The following is a description of a gene set: Genes up-regulated macrophages with MYD88 knockout: untreated versus 12h after M. bovis BCG infection. from publication Qualls JE, Neale G, Smith AM, Koo MS, DeFreitas AA, Zhang H, Kaplan G, Watowich SS, Murray PJ (PMID 20716764) Human Gene Set: GSE22935_UNSTIM_VS_12H_MBOVIS_BCG_STIM_MYD88_KO_MACROPHAGE_UP Nitric oxide (NO) produced by macrophages (MØs) is toxic to both host tissues and invading pathogens and its regulation is therefore essential to suppress host cytotoxicity. MØ arginase 1 (Arg1) inhibits NO production by competing with NO synthases for arginine, the common substrate of NO synthases and arginases. Two signal transduction pathways control Arg1 expression in MØs. First, a MyD88-dependent pathway induces Arg1 in intracellular infections, while a second Stat6-dependent pathway is required for Arg1 expression in alternativelyactivated MØs. We found that mycobacteria-infected MØs produce soluble factors that induce Arg1 in an autocrine-paracrine manner via Stat3. We identify these factors as IL-6, IL-10 and GCSF. We further establish that Arg1 expression is controlled by the MyD88-dependent production of IL-6, IL-10 and G-CSF rather than cell intrinsic MyD88 signaling to Arg1. Our data reveal the MyD88-dependent pathway of Arg1induction following BCG infection requires Stat3 activation and may result in the development of an immunosuppressive niche in granulomas due to the induced Arg1 production in surrounding uninfected MØs studied in species Homo sapiens, and this is the list of marker genes: BAAT, TTC16, ADAMTS8, EEF1AKMT1, SPINT1, SREBF1, DDX60, SERPINA3, RCSD1, NCAN (NCBI Gene Id 1463), DNAJA1, PLA2G1B, IKBKE, UBE2F, IFNG, HYAL3, UBE2H, SIM2, RYR1, MAPK10, CCDC71L, PTPN23, DRC1, SLC22A12, SGMS1, C1S, HRH3, B4GALT2, PCSK5, PCDH7, SNX22, PCBD1, CA13, GSDMC, GTPBP2, SSBP4, AHDC1, MEP1A, CPA3, OR5D18, SLC30A1, MBD3L1, LY6G6C, HOOK2, TMEM53 (NCBI Gene Id 79639), ADCY4, RPS6KA4, ZC3H15, TMEM45A, TTC39B, CAMKK1, LRRC4, RCN1, MISP, GAS7, TRAF5, DSCAM, DUSP11, C1QL1, NXNL2, FNBP4, CCL22, TAB2, VAPA, RCCD1, ETV4, TANK, SLFN12L, NOTCH3, FNDC3A, VASP, RGS17, SH3BP4, GRK5, MYF6, COL19A1, CA2, TENT2, SEPTIN1, FAM110C, CLCNKB, CCDC191, BATF2, KIFC1, KRT72, LIMD2 (LIM domain containing 2), GTF2B, TIMP3, TMPRSS11D, CAMKK2, ENPP3, ACTN2, PARP12, ATG16L1, VANGL2, PAFAH1B1, SAMD4B, PLS1, CD72, LGALS12, IGSF9, SCLY, GABRQ, ZNF239, OGFR, RPL39L, SLC10A6, BTG4, CTDNEP1, CAMK1G, NKX2-5, SOX14, GTPBP6, TBC1D10B, BARX1, TMEM183A, KRT81, ADORA2B, RCL1 (NCBI Gene Id 94533), HTT, LRRC8C, PGAM2, MAPK11, RGS9, IER3, PTGER4, PSIP1, AK1, CD200, MVP, RLN1, C11orf68, PDE3A, MOB3B, ABHD17C, PBX1, BOP1, TLR3, BRCA1, IL36A, CRB1, GNA14, PCBP1, IGF1R, CNGA2, FOSL2, KRT79, MAD2L1, CFAP298, C8orf33, CNTN4 (NCBI Gene Id 53943), GPR88, IFIT3, TYK2, IER2, TMEM131, SST (NCBI Gene Id 6750), AANAT, SHROOM3, SLCO1B3 (NCBI Gene Id 28234), ADAM11, FBRS, NOVA1, PPP3CC, ERO1A, CCNJ, GSPT1, PHLDA1, POMC, EGR4 (early growth response 4), DNAJB6, ADAM23, GTF2F1, UBE2E2, AXIN2, BTG2, GJB4 (NCBI Gene Id 2708), CBLN3 (cerebellin 3 precursor), RRP7A, AEN, HBB, INHBE, HPCA, IL4I1, SSTR3, TRPM5, REM1, SAA1, CP, GGT7, ABRACL, BID, HAO1, ADRM1, NUDT9, CD14, ALPL, CAMP (NCBI Gene Id 820), AVPR2, PTCRA